The following is a description of a gene set: Any process that stops, prevents, or reduces the frequency, rate or extent of vasoconstriction. species: Mus musculus Mouse Gene Set: GOBP_NEGATIVE_REGULATION_OF_VASOCONSTRICTION, and this is the list of marker genes: Dusp5, Itga9, Ahr, Bmpr2, Dock4, Lep, Arhgap42 (NCBI Gene Id 71544), Itgb1, Apln, Hif1a, Nos1, Svep1, Mtnr1b, Adm, Stub1, Dock5, Itga4, Mmp2, Cx3cl1